The following is a description of a gene set: Human Gene Set: REACTOME_TETRAHYDROBIOPTERIN_BH4_SYNTHESIS_RECYCLING_SALVAGE_AND_REGULATION Tetrahydrobiopterin (BH4) synthesis, recycling, salvage and regulation species: Homo sapiens, and this is the list of marker genes: CALM1 (NCBI Gene Id 801), DHFR, PTS, SPR, HSP90AA1 (NCBI Gene Id 89272), GCH1, AKT1, GCHFR, NOS3, PRKG2